The following is a description of a gene set: This event has been computationally inferred from an event that has been demonstrated in another species.<p>The inference is based on the homology mapping from PANTHER. Briefly, reactions for which all involved PhysicalEntities (in input, output and catalyst) have a mapped orthologue/paralogue (for complexes at least 75% of components must have a mapping) are inferred to the other species. part of: Regulation of Expression and Function of Type II Classical Cadherins electronically inferred by orthology from the curated human pathway studied in species Mus musculus Reactome Pathway: Regulation of CDH11 Expression and Function, and this is the list of marker genes: Jup, Ilf3, Adam19, Angptl4, Ctnnb1